Given this list of marker genes PEX26, RAB8B, PEX16, PEX5, PEX3 (NCBI Gene Id 8504), PEX19, here is a description of the gene set: species: Homo sapiens Human Gene Set: GOBP_PROTEIN_IMPORT_INTO_PEROXISOME_MEMBRANE The targeting of proteins into the peroxisomal membrane. The process is not well understood, but both signals and mechanism differ from those involved in peroxisomal matrix protein import.